The following is a description of a gene set: Mouse Gene Set: REACTOME_BILE_ACID_AND_BILE_SALT_METABOLISM species: Mus musculus Bile acid and bile salt metabolism, and this is the list of marker genes: Akr1c6 (NCBI Gene Id 83702), Amacr, Hsd3b7, Rxra, Acox2 (acyl-Coenzyme A oxidase 2, branched chain), Slc10a2, Hsd17b4, Slco1a4, Slc51b, Cyp46a1, Ch25h, Baat, Osbpl1a, Abcb11 (NCBI Gene Id 27413), Cyp7b1, Nr1h4, Acot8, Osbp, Cyp27a1, Osbpl2, Osbpl3, Ncoa1, Ncoa2, Cyp7a1 (cytochrome P450, family 7, subfamily a, polypeptide 1), Slc51a, Slc27a5, Slco1b2, Akr1d1, Cyp8b1, Akr1c21, Slc27a2, Slc10a1, Osbpl6, Scp2, Alb, Osbpl7, Osbpl9, Akr1c20, Abcc3, Stard5, Cyp39a1, Fabp6